The following is a description of a gene set: species: Homo sapiens Human Gene Set: GOBP_SYNAPTIC_VESICLE_DOCKING The initial (indirect) attachment of a synaptic vesicle membrane to the presynaptic active zone membrane, mediated by proteins protruding from the membrane and proteins of the presynaptic active zone cytoplasmic component. Synaptic vesicle tethering is the first step in this process., and this is the list of marker genes: SNAP25, SNPH, STX1A, RIMS2, UNC13C, STX1B, UNC13A, PPFIA3, BLOC1S6, RIMS1, UNC13B, TPRG1L, RIMS3